The following is a description of a gene set: species: Homo sapiens Human Gene Set: GOMF_ADENYLATE_CYCLASE_ACTIVITY Catalysis of the reaction: ATP = 3',5'-cyclic AMP + diphosphate., and this is the list of marker genes: ADCY2, GNAO1, GNAL, GRM7, CALM2, RAF1, GUCY1B1, CALM1 (NCBI Gene Id 801), ADCY5, ADCY9, GNAS, GNAZ (G protein subunit alpha z), ADCY1, ADCY8, ADCY6, ADCY3, ADGRV1, ADCY7, RGS2, GNAI1, ADCY4, CALM3, ADCY10